Given this list of marker genes ITPR1, SHMT2, FBXO7, PEX2, ATXN8OS, PIK3R5, MAPT, DARS2, SNCA, TNR, GBA1, ATXN7, TGM6, AGTPBP1, ANO10, GJC2, ATP2B3, NOP56, SYT2, SCP2, CHP1, TSPOAP1, ATXN1, VPS13A, PTRHD1, PLD3, DHX16, VAMP1, MRE11, ELOVL5, ATP13A2, PDYN, ALS2, SLC44A1, NDUFA13, AFG3L2, ENSG00000288330, ATXN2, PRNP, TMEM240 (NCBI Gene Id 647400), MECR, COQ5, here is a description of the gene set: Slow saccadic eye movements An abnormally slow velocity of the saccadic eye movements. Human Gene Set: HP_SLOW_SACCADIC_EYE_MOVEMENTS species: Homo sapiens